The following is a description of a gene set: Human Gene Set: HP_BRANCHIAL_FISTULA A congenital fistula in the neck resulting from incomplete closure of a branchial cleft. studied in species Homo sapiens Branchial fistula, and this is the list of marker genes: POLR1C, POLR1B, BCR, EYA1, CRKL, SIN3A, POLR1D, TCOF1, SIX1, MAPK1 (NCBI Gene Id 5594)